The following is a description of a gene set: Human Gene Set: GOBP_CHIASMA_ASSEMBLY The cell cycle process in which a connection between chromatids assembles, indicating where an exchange of homologous segments has taken place by the crossing-over of non-sister chromatids. studied in species Homo sapiens, and this is the list of marker genes: MSH5, RNF212, UBE2B, CCNB1IP1, SYCP1, BRIP1, RNF212B, TEX11